Given this list of marker genes STX4, ANKRD17, NKD1, IGFBP6, LBX2, SKI, RB1CC1, VSNL1, CDK5R1, CASTOR1, FFAR2, SLC1A3, TMEM198, TRIM62, TNFRSF19, MMD2, EPGN, KDR, RC3H2, BAX, MIR342, GADD45G, MIR146A, NID1, SFRP4, MIER1, HFE, PTP4A3, TXK, CCDC134, MIR138-1, PLA2R1, SLC9A1, SLC30A10, SPATC1L, MAPK1, ARHGEF10, CLU, F11R, GPRC6A, PTPRJ, BCL2L14, DEPDC1B, MLST8, PROS1, DAPK3, PPP2R1B, CSNK1A1, KCTD13, APOE, GHRL, LTK (NCBI Gene Id 4058), NEO1, TTI1, HCLS1, MIR501, CSH1, GAB1, PIK3AP1, PAK2, PPP2R3A, ZDHHC3, CDCA8, SOS1, ATP6V0C, HIF1A, SLC44A2, BDNF (NCBI Gene Id 627), LY96, TEDC1, GJA1, MCU (mitochondrial calcium uniporter), NPR1, DLG5, SLC7A10, BAD, PDGFRA, TBX1, FZD9 (frizzled class receptor 9), DDX1, RIMS2, HINT1, C1QTNF3, NCSTN, EPHA4, IL19, CCN1, CIB1, MIR182, ATR, TGFBR3, MPC2, CHERP, TAOK2, ELAPOR2, FGF2, PIP4P1, IQGAP1, CSF2RA, DDX5, TRAF2, PRKAR1A, RAB3GAP1, TAB1, IKBKE, EIF2A, GLIPR2, FOXP1, YAP1, ACSL4, VAMP2, PTPN6, SLC4A8, CLEC16A, LTBR, TTC23, TLR6, NOG, MIR26A1, SCHIP1, MAP3K11, GAS6, CD40, GNA11, CNOT9, POU5F1, CD74, ROBO2, PTN, F7, MIR210, TGFBR2, GHRH, HTR2C, MIR92A1, LRRK2, AURKB, ROCK2, NMB, CFTR, FAM53B, LGR6, GPR89A, ECE1, CDK10, CCN3, GOLPH3 (golgi phosphoprotein 3), HDAC3, GUCA1ANB-GUCA1A, ELANE, GAS8, WBP2, CTH, TICAM2, FRMD6, DRD3, IFNL1, ZBTB7B, HDAC1, SLC2A2, MIR19A, GRIN1, PRKN, SRMS, NINJ1, SERP1 (NCBI Gene Id 27230), TNXB, FBXW11, PECAM1, MIF, BMP2, ASXL2 (ASXL transcriptional regulator 2), NTRK1, CRADD, FCGR2B, LFNG, GPR155, GOLT1B, ADCY1, PUM1, CDKN2A, MMP2, CLSTN2, CC2D1A, MYD88, SULF1 (sulfatase 1), MAZ, WLS (Wnt ligand secretion mediator), FGF22, TNKS2, TIFAB, GAL, TP53, PELI1, ESM1, PTBP1, SLC35C2, STMP1, USP8, MLLT3, PPARD, TMOD2, CSF1R, ATM, PPP2R5B, MMP8, SECTM1, MIR519D, GRIA3, BMP6, PTPN23, NEK7, MIR1246, LRP4, BRD4, FGF20, COL3A1, RASGRF1, TPD52L1, TRIM56 (NCBI Gene Id 81844), NSG1, DYNLL1, BAMBI, RHOC, JUND, WNT5A, AMH, SHH, FAM107A, SKIL, HSPA1B, MIR320C1, HPX, BAIAP3, S100A7, ATAT1, NPY5R, NGFR, CDON, AVPR1B, FNIP2, SOX2, IL12B, LRG1, MSX2, LAMTOR2, MME, KLK5, SBNO1, BMPR1A (NCBI Gene Id 8035), FGF19, SCUBE3, JAK2, ADAM17, MAPK8IP2, CX3CR1, NLGN3, PPP5C, PRKACA, NDP, IFIT5, TGFBR1, ITSN1, GRIN2B, RASGRF2, STK19, AGER, OPRK1, STAMBPL1, CCL2, F2RL2, HMGB1, TRAF3IP2, STAT3, NOTCH2NLA, BCL2L11, LRCH4, FRMD1, DVL2, NOX4, FLNA, RPS3, NR0B2, IGFBP4, LATS1 (NCBI Gene Id 9113), CHD5, TENM1, ARHGAP6, ABAT, THBS1, ECM1, RXRA, CAMK2A, ROBO1, FGF21 (NCBI Gene Id 26291), ADRA1D, CD14 (NCBI Gene Id 929), TRIM39, ACTA2, TRPM5, MPP2, SORBS1, ATF3, HAVCR2, CTSH, WNK1, C1QTNF12, INSR, GAS2L2, TRIM44, F2RL1, MIB2, PDE6G, MIR1260B, CDKN2AIP, PAGR1, ZBED3, CRK, GIPR, SIRT6, LACRT, RNF220, MTCH2, NOTCH1, LANCL2, ANO1, GATA4, UBE2I, GFAP, CXCR4, SRC, KMO, ECT2, SIRT3, MIR10A, ORAI1, MUL1, CRLF3, TRAF5 (NCBI Gene Id 7188), NPS, CCL4, SNW1, CRLF2, RAC1, FABP5, RIMS1, AMBRA1, LPAR2, PLA2G5, EPHA8, TXNDC15, TAB2, SDCBP, RAPSN, ADA, IL10RA, SHOC2 (NCBI Gene Id 8036), ACVR1, SMAD5-AS1 (SMAD5 antisense RNA 1), CASR, DDX21, RASSF2, GDI1, FAM110C, C5AR1, CCR1, FCRL3, ALOX15, SESN2, HSP90AB1, PPM1B, EMP2, LAMTOR5, KMT2D, HHEX, HIC1, CNTN2, GIP, PRKCE, SHKBP1, PRDM15, ATF6, ASCL1, SLC18A3, GREM1, MARCO, IL18R1, KLHDC10, SOX11, MACF1, PMAIP1, EGF, LURAP1, TRAF7, FZD7 (frizzled class receptor 7), NMUR1, ENHO (energy homeostasis associated), LIN28A, EPHB2, ADGRV1, RHEB, LAMTOR3, SPRED2, EDNRA, MIR541, TNFAIP3, WWC1, TRIM16, ADRB3, MIR449A, CLEC4D, MBD2, FKBP8, AGO1, HRAS, OPRM1, INHA, ECRG4, GPR27, RIPK2, RTN4, JRK, RSPO1, HYAL2 (NCBI Gene Id 8692), PLA2G6, DDIT3, BECN1, FER, SPRING1, SMOC2, SORL1, INPP5F, TNFSF10, CCL21, HTR2A, STXBP1, GRIA1, DYNC1LI1, ADIPOR1, CHRNA7, GABBR1, MIR126, IL23A, PELO, DGKD, PTGIS, HIPK2, FERMT2, LRRK1, SLC35B2, CACNG3, NUCKS1, C1QTNF4, LRRTM1, STK4, LIF, TMEM101, PML, SMCR8, CDKN2B, ADAM10, TLR7, GDF11, RTKN2, FGFBP1, GSKIP, CCDC88A, PRKCD, TLR4, EPN2, TM7SF3, AIMP1, UBE2O, ARNT, MIR18A, STING1, DRD2, LAMA2, SAMTOR, USP32, PDCD4, MAPK8IP3, NEK6, ITPR1, GLCE (glucuronic acid epimerase), LGMN, ARRB1, ITPKB, GPR62, ANKRD6, STX1A, RAPGEF4, TXN, MIR29A, CMTM3, TESPA1, CYBA, FSHR (NCBI Gene Id 4959), ZAP70, MIR145, GRM4, GCNT2, USP9X, TRH, PDE8A, CASS4, CCR2, NCKAP1L, MEN1 (menin 1), KIF5B, INHBB, GLI1, MAP2K6, AKT1, EDA2R, UCN3, TAOK3, CX3CL1, CASP2, KSR2, EZH2, FRS2, CPNE1, MIR675, GFI1, NFKB1, MARCHF5, RRAGD, LPAR1, NOTCH2NLB, DCDC2, INTU, CSNK1E, XIAP, NFATC4, WAC, DCN, IL10RB, CAMTA1, UNC5CL, TRIP6, MIR181B1, FGR, TSPYL5, PEA15, MESP1 (NCBI Gene Id 55897), AACS, RWDD3, MERTK, RNF13, CHSY1, S100A4, TRPV4, TNFSF11, TMF1, EI24, MAP4K1, CRHR2, NPTN, GPER1, NDRG4 (NCBI Gene Id 65009), MYDGF, LGR4, WNT10B, SNAP25, STK3, TNFRSF1A, ABL1, SELP, TGM2, LAPTM5, NR3C2, AGTR2, DVL3, LARGE1, TRIM55, INCA1, CASP8, IRF3, GPR158, OCIAD1, GATA5, BOK (NCBI Gene Id 84558), MIR29B1, TRIM41, FOXA1, EDNRB (endothelin receptor type B), FGF10, IHH, OCIAD2, PTEN, UBE3A, IL1R1, CYP46A1, MAP2K1, CHRM3, LBP, IFT172, MAL, SYT14P1, SEH1L, CYP27B1, DEDD2 (death effector domain containing 2), VAPA, TAC1, CTSC, GRIN2C, RNF111, RSPO2, MMP9, JUN, FRMD7, MIR16-1, SH3RF3, CHGA (NCBI Gene Id 1113), BMP7, CAMK2D, NFAT5, NGF, FGB, GPR101 (G protein-coupled receptor 101), TGFB2, TWSG1, SERPINE2, CACNG5, NPSR1, KLF14, INHBA, RIPK1, NUMA1, CA7, ARMC9, MFHAS1, TRIM15, UNC5B, FKBP1A, MMP12, YWHAE, SNCA, ARHGAP8, GDF6, SIAH1, DRD1, GADD45A, AMER1 (APC membrane recruitment protein 1), ICAM1, GPC3, LAMB2, TSHZ3, CDKL5, PIM1, ITGB1, FGF5, NUPR1, SHISA5, AGPAT2, ILDR1, FGF8, PDX1, CSHL1, WNT3A, ATOH8, NENF, NECAB2, SYT12, NRP1, GPS2, SCRIB, TCF7L2, BTBD10, ILK, PARP9, BIRC5, GNAI2, NSF, DHX15, NOD1, PDE8B, IL1B, BAG4, FGF9, PRKD2, DDR2, MINK1, CORO7, PDGFB, ARL6IP5, ACTN4, MADD, CSF1, TMEM9B, WDR24, PRMT1, TNR, MAP4K4, TRIM22, IL26, PLXNB1, GORAB, PHB2, CREBBP, TRAT1, TNFSF12, RC3H1, CREBRF, AJUBA, CALM1, WWOX, DRD5, MIR27B, SMAD2, MIOS, PPP2R1A, PLA2G1B, RTN4R, MAPKBP1, SLC20A1 (NCBI Gene Id 6574), BAIAP2, ARHGEF3, CAV1, PCK2, ZNF423, PRRT1, MYC, TNFSF15, RICTOR, TNIP2, OSBPL8 (oxysterol binding protein like 8), IRAK1BP1, IGFBP5, ASPM, NALCN, ITGB1BP1, NMUR2, NDFIP2, ADRA2B, NR2C2 (nuclear receptor subfamily 2 group C member 2), MIRLET7B, IL20RA, RAD9A, KLF2, RPL37, PFKM, LAMTOR1, FGFR4, POR, MAVS, UBR5, BRAF, SLC46A2, ERBB3, BBC3, HBEGF, DHH, TBL1X, SRARP, ADGRA2, GPR183, PRR5L, MIR20A, PSG9, NR1H3, UBR2, HTRA2, PRKD1, VWF, FGF18, NLGN1, TP53BP1, SHC1, CDK5RAP3, ZSWIM2, TTK (TTK protein kinase), PIAS4, ZDHHC17, HAX1, MIR10B, CALM2, DLG4, S100A9, EDA, ADTRP, PIK3CB, CCDC22, RET, SFPQ, ADGRG1, RAB34 (NCBI Gene Id 83871), CA2, PRKCI, MSX1, CALCR, TMEM106A, FLT1, GKAP1, TAF6, PJA2, RBPJ, NRGN, NEPRO, MYB, RELL2, PTGDR2, STK36, DDRGK1, ULK3, CCDC88C, NCK2, NAIP, CCR7, PRDX2, PINK1, LYPD6 (LY6/PLAUR domain containing 6), ZDHHC5, SIRT1, ADRB2, SPAG9, RNF185, SKOR2, DUSP15, HPSE (heparanase), WDR59, SHOX2, NDC80, FERMT1, MN1, LIMS1, TLR3, TRIM52 (tripartite motif containing 52), THRA, OTUD7B, PSEN1, GPRC5B, GPC5, EDN2, HLA-DRB1, CSNK1D (NCBI Gene Id 1453), PPARG, PAK1, EDN3, CD86, SPIN1, MAPK8, MECP2, TERF2IP, GUCY1A1, PRNP, PDCD10, LRRC8A, HES1, ABCC8, AGR2, ROR1, ZBP1, MIR186, CRKL, MAPK8IP1, CTNNA1, S100B, NTRK3, ZNF622, FGFR3, AARS1, TRPA1, JMJD8, FNTA, C22orf39, MAP3K7 (mitogen-activated protein kinase kinase kinase 7), LILRA5, CSPG4, CSF3, DIXDC1, CYFIP1, EIF5A, PARK7, SLC24A2, ABCA7, EPS15, RRAGB, IGF1, RIPK3, DIRAS2, APOA1, PIBF1 (NCBI Gene Id 10464), PSMD9 (proteasome 26S subunit, non-ATPase 9), KCNN4, TMEM100, PPP2CA, LMO3, FLOT1, ANGPT1, APLN, GRM5, TP63, HSPA1A, NTF3, OXCT1, BNIP2, PLA2G3, CACNA1B, HMOX1, AVPR2, TRADD, CD300LF, HCRTR1, CDH13, TNFAIP8L3, LILRB2, MBIP, PHIP, DDX3X, GAREM1, TAB3, FLT4, RNF183, PLCG2 (phospholipase C gamma 2), UBE2K, NAGK, KLK6, MAP3K5, GRM2, HEXIM1, IFI35, DOK5, CCAR2, WDFY1, HGF, RELL1, CNTN6, DOK4, SEMA5A, AXIN1 (NCBI Gene Id 8312), LSM14A, RGS4, CSNK1G3 (NCBI Gene Id 1456), NOD2, OASL, DSTYK, MIR26B, GSX2, LATS2, DDT, HIP1R, MFNG, NDFIP1, CCN2, TYROBP, SNX5, CARD11, FBXL15, MIR337 (microRNA 337), ZNF385A, AKAP6, MIR1-1, NODAL (nodal growth differentiation factor), RPS15, TLR2, POGLUT1, CLEC7A, MIR320B2, ADCYAP1, ING5, GBP2, GSK3B, OXT, EVC, CANT1, GPR4, VNN1, PAIP2, NDST1, SERPINA12, RAB8B, NOS3, FAF1, RYK, ANKRD1, BCLAF1, MIR183, CD226, SORBS3, ZEB2, UBE2V1, AKAP12, CCN4, PRLR, RPS20, MYOC, GRIK2, RAPGEF2, S100A13, TIRAP, NFAM1, ERN1, UBE2B, P2RX3, NPY, MAOA, HMGCR, FGF17, GPR137, PPP3CA, ZDHHC2, TSPAN6, RGS14, FOXD1, MGAT5, GDF7, OTUD5, CD36, RACK1, KRAS, IFNGR2, FYN (NCBI Gene Id 2534), FLT3, GADD45B, IL6ST, WNT1, PPM1A, SP1, DENND2B, FGA, CBL, GID8, CA8, SYBU, STK25, C1QTNF1, USP15, CARD16, AKAP13, RALA, ZRANB1, CD38, PPM1N, ZC3HAV1, PELI2, FGG, GPR37, G0S2, SEMA7A, ENG, GBP5, SEMA4C, APOL3, INCENP, WNT5B, AFAP1L2, AAK1, FRAT1, SERPINF2, PTK6, SALL1, DGKQ, SLC24A1, ACKR3, TELO2, ING2, YTHDF1 (NCBI Gene Id 54915, YTH N6-methyladenosine RNA binding protein F1), TRIM5, STK11, NLE1 (NCBI Gene Id 54475), HCST, PUM2, PROX1, PTPN22, TSPAN14, ABRA, POMC, PRAG1, CD180, CD3E, NAMPT, HTR6, CD4, ARRB2, MIR320B1, PTPRC, SPRY2, VCP, MIR30B, SMARCB1, ADRB1, MALT1, TYK2, ADRA1B, KLHL22, NET1, XBP1, AVPI1, DAAM2, MIR320D1, LMCD1, GPR137C, HES5, NUP62 (NCBI Gene Id 51551), CD40LG, C2CD2L, SCT, IRAK4, SH3RF2, SCUBE1, PIK3R5, COL1A1, SLC2A10, ROCK1, NLGN2, AKR1C3, CD80, GSK3A (NCBI Gene Id 2931), OSBP, CCL5, ADRA1A, TFG, ITPR3 (NCBI Gene Id 3710), SLC15A4, TNF, PRL, DUSP19, CAPRIN2, STYXL1, SPECC1L, AUTS2, FLCN, USP4, MYORG, GRP, P2RY1, ADCY8, VAMP3, MAD2L1, PPP3CB, CRB2, PTPN2, ALOX15B, GPR37L1, HUWE1, CD27, TRIM38, WNT7B, GPX1, KITLG, AKAP5, NELFE, RAMP3, LGALS9, HAP1, ARAP1, MIR96, SMAD4, KLB, CHI3L1, VAMP7, TSLP, RUNDC3A, NRDC, ZCCHC3, PIK3CG, MID2, CDKN1C, GHRHR, TBK1, GOT1, ISL1 (NCBI Gene Id 3670), NMNAT1, IL6R, TYRO3, WNK2, GRB10, CFLAR, ING4, NPNT, NF1, FIS1, GLUD1, WNT7A, BMP4, TGFA, DSC2, ADORA2A, IL10, PARP14, NHERF1, STAU1, VEGFA, LIMS2, SKP2 (NCBI Gene Id 86997), ERFE, FN1, TNIK, PPP3R1, ALKAL2, MST1R, RPL23, BTK, EGFR, GALR1, IRAK1, PYHIN1, FAS, BRCC3, NMU, CRIPTO, TUBD1, S100A12, AGT, ALKAL1, MAP3K4, DDR1, SH3RF1, PRP4K, PRKRA, PDE6H, TREM2, IQCJ-SCHIP1, MIR181D, ARFGEF1, SPPL3, FGF23, SCIMP, MIR181A2, RETN, SYT1, PTH, BGLAP (NCBI Gene Id 632), BST2, SEPTIN4, MIR95, PRXL2C, ADORA2B, RPS7, MAP4K2 (NCBI Gene Id 5871), LTA, SPRED1, ADAM8, PRKCA, DAB2IP, AGO3, TRIM13, VPS35, TLR9, USP29, DLL1, CD19 (NCBI Gene Id 930), CYP1B1, NRXN1, RFX6, MIR433, NR2C1, ZDHHC12, DIRAS1, MAP3K3, ACVRL1, CDC42, CSNK2A1, LYN, RBCK1, ARK2C, SYNPO2L, PARP1, WNT16, PRKCB, FGF1, PDIA3, C3, TRAF6, MAP2K7, ITM2C, CUL1, PLAGL2, BCAR3, PSMA6, TLR8, TRAF4, ADORA1, TRIM26, TREML4, STX3, HSP90B1, RSPO4, FFAR4 (free fatty acid receptor 4), ERBB4, TFR2, ADAMTS3, PIK3CA, CXXC5, CAV2, ATP6V1C2, RNF146, SPHK1, TTC21B, PICALM, CARD10, INAVA, C18orf32, VAV1, IQGAP3, HDAC6, PPP1R15A, BIRC8, TRIM8, SERINC3, STOX1, TGFB3, PIK3R1, DUSP22, EIF2AK4, SMARCA4, USP17L2, BCAP31, CUX2, ADIPOQ, GAPDH, CITED2, NCK1, LAMTOR4, SLC19A1, MIR324, CD81, LCK, ITGB3, FGFR2, PHB1, RAB29, PPP3CC, DISC1, SH2B1, RNF167, MTDH (NCBI Gene Id 92140), USP1, KSR1, LAT, NPPA, HOMER1, DHX58, NNAT, PDGFC, PDCL, ITGA8, IL5, ACVR2B, LAMB1, TMEM33, NLRP6, JCAD, ACP3, TSPAN5, CAMK2B, DKK1, RNF39, CDH2, CACNG2, CITED1, SLC8A2, TNS3, PYCARD, GRIN2A, MIR296, RAP1B, GRIN2D, BMAL1, CD63, CSNK2B, MIR320D2, ZDHHC9, CTNNB1, PROK1, LPAR3, CDH5, CTSD, IGF2 (NCBI Gene Id 492304), EFNA5, WDR48, NETO1, ADCYAP1R1, TNFRSF11A, ARRDC3, REL, ADRA2A, HSF1, ZNHIT1, SLC2A4, FOXL2, IRF7, TNFRSF10B, APP, ZDHHC13, ARHGEF5, BMPR1B, LGALS1, RECK, WASF1, TBL1XR1, RELN, PPP1CA, MT3, TMED4, NPPC, THPO, FPR2, MIR320A (NCBI Gene Id 407037), DKK2 (NCBI Gene Id 27123), DYNC2H1, SSH1, PTPN11, JAG1, SLCO3A1, MAD1L1, TEK, NKX6-1, TEDC2 (tubulin epsilon and delta complex 2), SHISA7, MCL1, KANK1, VAMP8, SLC38A9, MIR15A, GPBAR1, LEF1, KIAA0319, HTT, PIH1D1, BCL10, RELA, LGR5, NACC2, TPR, JAG2, DHX36, ZMIZ1, NKX3-1, PDE9A, BVES, TMEM108, RPH3AL, SEC13, MAPRE2, RIT2, DAB2, NOTCH2NLC, NR1H4, AKT3, SOX4, GHR, IQSEC2, FBXW7, GUCA1A, F10, FFAR1, MYOCD, ZC3H3, WNT4, IFNG, STAP1, GPR68, SMAD3, BIRC7, ZC3H12A, TOR2A, FXR1, IGFBP3, PIM2, ARC, MIR1224, DACT1, PLAUR, MIR24-1, NTRK2, SLC30A8, SLC15A3, SHANK2, P2RY12, LRRC19, TBX20, TGFB1, GEN1, NOS1, ITGAV, CYP19A1, RGL2, ATP6AP2, VAV3, CAMK2G, FGFR1, MEF2C, MAP3K10, FBH1, MCF2L (NCBI Gene Id 80044), CYFIP2, NUP93, P2RX4, FZD10, APELA, PFKFB2, SYK, RAP1A, LY86, CARTPT, CHP2, BANK1, NTS (neurotensin), IL6, MESD, RBP4, LURAP1L, AXL, PKD2, ADCY10, MIR545, TGFB1I1, ITGA1, SLC39A10, KCP, DTNBP1, EEF1E1, NEDD4, PLA2G2A, MLXIPL, KIT, AGPAT1, TAOK1, SFRP2, EDAR, INS, CYLD, MIR140, RFNG, P2RX2, RPS12, USP50, NLRP3, ANXA2, HDAC2 (histone deacetylase 2), CASP1, ERP29, CCL3, TNFSF14, ADAM9, CDH3, MIR421, NADK, RALB, PLCB1, THRB, NOTCH2, RRAGA, MAPK9, HCAR2, FGF7, LAMC1, UCN, PCP4, EXTL3, F2, TUNAR, P2RX5, GPR137B, MAGED1, IL11, LTB, NMI, SCARB1, RASL10B, MAT2A, IL7R, BIRC2, SQSTM1, MAP3K12, LEP, PCDH11Y, CSNK1G1, ATP2C1, CACNG8, TRIM32, UCHL5, RXRB, CARD14, TICAM1, TTI2, IRAK3, VTN, ERBB2, ALS2, USP34, PRRX1, RRAGC, SMO, TERT, TRPM4, MRAP2, OTUB1, CARD9, APAF1, RSPO3, PBXIP1, CHUK, DNAJC27, PAQR3, TRIM25, EFNA1, FAM83B, SMURF2, C1QBP, TIFA, CSH2, CD28, GDF2, MBD5, PLEKHG5, FGF3, TAF1, MIR23A, SEMA3A, NLRC5, SEMA3E, KIF7, LTF, PPP3R2, RNF31, SLC1A1, FNIP1, IL34, ASXL1, PRKCZ, CXCL17, LARS1, NRG1, SRPX, IGF1R, NLRP12, ACVR2A, SLC8A3, AR, NEU3, CTBP2, SLAMF1, LGI1, GHSR, STX1B, LITAF, FGF4, VAV2, GRM1, WNT3, SEMA4D, CDC73, MIR212, GIPC1, TSC22D1, SHQ1, HAND2, BMPR2, MED1, CRACR2A, RUVBL1, FLOT2, CLEC6A, SOD1, RASGEF1A, MOS, IGSF11, BMPER, VDR, NGLY1, TBC1D24, FGF6, S100A8, NEK10, TACR1, PTK2, GATA3, DRD4 (NCBI Gene Id 1815), FMR1, IRAK2, CENPJ, MIR27A, HTR2B, CALR, TASL, CACNG4, CLSTN3, IAPP, LOXL3, GPR55, CSNK1G2, UBE2N, ZNRF1, NR2E1, OSM, OR2AT4, SLC39A14, FADD, KLK14, GH1, PDGFRB, CRH, CIBAR1, SLITRK4, GH2, MAP2K3, MIR221, PRKCH, NRK, ITGA5, RHOA, PRKCG, PLEKHA4 (pleckstrin homology domain containing A4), DOC2B, ADAMTS20, APPL2, F3, IRGM, RPL11, KCNK6, CAT, AKR1C2, P2RX7, CAPN10, DLL4, MIR320C2, TNFRSF12A, DLX5, MTURN, JUP, ADRA2C, KL, MIR199A1, PRMT5, BAK1, CACNG7, ADISSP, PDPK1, PTK2B, BMP2K, ADNP, MIR320E, ACVR1B, KNL1, SULF2, IL1A, EP300, FGFBP3, BMP10, TRIM3, TACR2, GSDME, RAF1, MAS1, CUL3, SHANK1, PIN1, NEUROD2, PLPP3, SIK3, PRKAR1B, GUCY1A2, TMEM132A, IL18, GFRAL, USP27X, MC1R, LRRTM2, PRR5 (proline rich 5), RBM47, RSAD2, ZDHHC1, EPO, DDX60, TPBG, FASLG (Fas ligand), RPS6KB1, VEGFB, TCIM, RGS2, BLK, PIK3R6, RASGRP1, CALM3, PAFAH1B1, P2RY6, ALOX12B, SPI1, C10orf71, MARK4, NRARP, F2R, GCG, CLSTN1, MAPK3, PDGFD, USP47, FGF16, CASP10 (NCBI Gene Id 843), BID, GDF5, IKBKG, IRS2, TARDBP, MTOR, NOX1, CCL19, GPLD1, TFRC, TLR1, PDGFA, CAVIN3, LAMA1, NLK, MAP3K20, SFRP1, EIF2AK2, SCEL, CRBN, ZNF268, RPTOR, XRCC3, CTDNEP1, MID1, IFNB1, PLK2, STK39, EDN1, RASD2 (NCBI Gene Id 57347), GDF15, IKBKB, SASH1, SHARPIN, TP73, UBB, MIR346, CREB1, SNX4, ALPK1, OGT, DHX33, SELENOT, CTNS, IRS1, HIP1, MIR21, NEGR1, SHANK3, TIAL1, GPNMB, CCBE1, RPL26, LIPA, SPP1, PPIA, NECTIN2, PHPT1, CD44, TM2D3, SPIN4, UBD, PTK7, BMP5, MYRIP, RBX1, TMEM9, TNKS, MICU3, PTPN1, BIRC3, GCK, MRAP, CASP4, IL7, DVL1, DOK7, TRIM6, here is a description of the gene set: Human Gene Set: GOBP_POSITIVE_REGULATION_OF_SIGNALING studied in species Homo sapiens Any process that activates, maintains or increases the frequency, rate or extent of a signaling process.